The following is a description of a gene set: species: Mus musculus Genes predicted to be targets of miRBase v22 microRNA mmu_miR_6944_3p in miRDB v6.0 with MirTarget v4 prediction scores > 80 (high confidence targets). Mouse Gene Set: MIR_6944_3P from publication Chen Y, Wang X (PMID 31504780), and this is the list of marker genes: Nhlrc2, Ddx6, Dner, Ildr1, Ror1, Zmym3, Lamp3, Ier3ip1, Twsg1, Serpinb13, Togaram1, Osbpl8 (NCBI Gene Id 319994), Camk2d, F830016B08Rik, Kctd12, Myt1, Ccdc6, Tfpi2, Tekt3, Cnksr2, Mafg, Dmxl2, Luc7l3, Chic1, Sun1, Trim44, Srfbp1, Nkrf, C1ql3, Pgr, Sp8, Shpk, Dcun1d1, Ccr3, Arfip1, Dmc1, Piwil1, Ppil3, Tent5a, B3galnt1, Fyco1, Slc7a1, Spats2l, Ranbp3l, Caprin1, Dip2a, Hyls1, Sfpq, Pcsk6, Btbd10, Appbp2, Rbbp8nl, Trim12c, Prpf3, Ralgps2, Ifi213, Dynlt3, Ptar1, Epor, Apln, Ranbp9, Pbx1, Ranbp6, Tmem135, Cwc25, Wdr48, Ppid, Pdcd6ip, Dyrk1a (NCBI Gene Id 76465), Creb1, Mex3c, Ptchd4, Ano5, Lrig1, Pnn, Pde5a, Ankrd12, Srek1, Cimip2a, Map3k1 (mitogen-activated protein kinase kinase kinase 1), Msx2, Nfat5, Sar1a, Zfp518a, Tsr2, Fndc3b, Ppp2r2b, Rai1, Trmt12, Tnrc6b, Phlpp1, Cdyl2, Tpm1, Urb2